The following is a description of a gene set: Genes up-regulated in B lymphocytes: PL2-3 (Chromatin IC) versus anti IgM and CpG oligodeoxynucleotide 1826. species: Homo sapiens Human Gene Set: GSE6674_PL2_3_VS_ANTI_IGM_AND_CPG_STIM_BCELL_UP We have previously shown that rheumatoid factors (RF) produced by Fas-deficient autoimmune-prone mice typically bind autologous IgG2a with remarkably low affinity. Nevertheless, B cells representative of this RF population proliferate vigorously in response IgG2a/chromatin immune complexes through a mechanism dependent on the sequential engagement of the BCR and Toll-like receptor 9 (TLR9). To more precisely address the role of both receptors in this response, we analyzed the signaling pathways activated in AM14 B cells stimulated with these complexes. We found that the BCR not only serves to direct the chromatin complex to an internal compartment where it can engage TLR9 but also transmits a suboptimal signal that in combination with the signals emanating from TLR9 leads to NF-kappa-B activation and proliferation. Importantly, engagement of both receptors leads to the upregulation of a group of gene products, not induced by the BCR or TLR9 alone, that include IL-2. These data indicate that autoreactive B cells, stimulated by a combination of BCR and TLR9 ligands, acquire functional properties that may contribute to the activation of additional cells involved in the autoimmune disease process. from publication Busconi L, Bauer JW, Tumang JR, Laws A, Perkins-Mesires K, Tabor AS, Lau C, Corley RB, Rothstein TL, Lund FE, Behrens TW, Marshak-Rothstein A (PMID 18025183), and this is the list of marker genes: EYA2, TAPBPL, SRSF2, PPP1R15B, PPP2R1B, BPNT1, IL21R, SNX33, PPARG, SNX17, WDR6, COMMD7, RAB19, ZMYND19, PRKAG2 (protein kinase AMP-activated non-catalytic subunit gamma 2), TBKBP1, CTRL, TNNI3, CD82, ABI3, FRMD8, PREX1, INPP5D, SSR2, FBXO33, DNMT3A, SLC37A3, SAPCD2, ARRB2, BRS3, XRCC2, SUCLG1, NAA40, INTS14, SYNCRIP, EPAS1, TK1, TUBB4B, C1QA, ID2, SMIM15, CASP7, PYGO2, ARMCX4, RAP2C, RRP1, TEDC1, ATP8B2, DIS3, SUSD3, LTA4H, ATP6V0A2, CDCA4, LYPLA2 (lysophospholipase 2), RAB1B, LCP2, LNPK, UQCR11, IL12RB1, MRPL51, CDC6, SPTLC1, ZNF207, CNR2, CDKN2AIPNL, PIGR, POLR3K, WASHC1, SLA, CHRNB2, NT5C2, PDGFB, CHST14, LAMTOR4, ZBTB1, DNAJB1, CXCR3, SGK1, PXYLP1, RGS3, AXIN2, ANP32E, AKR1C4, SLCO4A1, PROS1, NME1, IRF1, PDCD1, RPS6KA5, DTNBP1, SCAMP3, AMPD2, CPSF3, TMEM39B, TMEM164, SASH3, TNK2, PTK2B, HRC, ALKBH4, AK2, GCM2, RBM12, POLR2D, RPA2, GDPGP1, IFI30, VCP, ETAA1, DUSP10, FHL2, ABTB3, PFN1, C8orf58, RASSF5, NHLRC2, MAD2L1BP, ATP5MC1, NMNAT3, RAPSN, LANCL2, PAG1, SEMA4A, MID1IP1, TM6SF2, LRRC69, AQP9, TM6SF1 (transmembrane 6 superfamily member 1), FNBP1, AKR1C3 (NCBI Gene Id 96424), SRSF1, CCNE2, LFNG, RXRA, RRM2, LMNB1, NEDD9, GRAMD1B, ACP3, ZAP70, PRSS37, CRYBG2, INTS5 (integrator complex subunit 5), TMC6, DYRK2, ZNF43, MAF, HNRNPM, RAB32, SPMIP8, MAOA, ABHD16A, EMG1, HESX1, IER5, PARVG, GOSR2, HIP1, RAB27A, TSPAN14, ASB2, DUSP7, AKT2, RASL11B, RTF1, ACBD4, RPS6KA3, ELMO2, SLBP, SNX9, ST8SIA4, RANBP6, RNF166, IL4, ATIC, PPIH, SNX15, PSMC2, GLIPR1, IQUB, KLHDC3 (kelch domain containing 3), PSMC1, OLFM1, DDX11, C9orf152, UNKL, ZNF367, SPR, PDP1, NANP, VSIR, ZFTA, LASP1, DLST, PRAP1, RASAL3, S100A5, DPP3, SAE1, AIP